The following is a description of a gene set: Human Gene Set: HP_HEMIVERTEBRAE Hemivertebrae Absence of one half of the vertebral body. species: Homo sapiens, and this is the list of marker genes: LRP4, SIX6, STAG2, SOX2, MYH3, FGFR1, MBD5, TBC1D24, SF3B2, SON, ACTB, HES7, TBX6, DLL3, ATRX, SUFU, FANCB, KMT2D, WNT7A, ATP6V1B2, LYSET, MADD, H3-3B, DPP9, PTDSS1 (NCBI Gene Id 9791), B3GLCT, IKBKG, MEG3, PTCH2, ORC1, GLI3, RIPPLY2, PUF60, DLK1, CCDC22, EBP (NCBI Gene Id 139151), RAD21, WASHC5, ROR2, VPS35L, FZD2, TMCO1, KYNU, CAPN15, RTL1, GNPTAB, POR, DVL3, PAICS, CHD7, PTCH1, DVL1, DPYSL5, WNT5A, KDM6A, SEMA3E, CDK10, MBTPS2, JAG1, MESP2, EIF5A, TBX2